The following is a description of a gene set: species: Homo sapiens Human Gene Set: WP_NOVEL_INTRACELLULAR_COMPONENTS_OF_RIGILIKE_RECEPTOR_PATHWAY Novel intracellular components of RIG-I-like receptor pathway, and this is the list of marker genes: MAP3K7, IFNK, CASP8, TNF, CASP10, DHX58, SIKE1, TKFC, STING1, IFNE, TRAF3, TBKBP1, DDX17, TRAF2, ISG15, ATG5, CYLD, ATG12, RNF125, CXCL10, IKBKG, IFIH1, RIGI (RNA sensor RIG-I), MAVS, IRF7, AZI2, NFKB1, MAPK12, NFKBIB, MAPK11, TRAF6, MAPK13, DDX3X, TRIM25, MAPK14, CXCL8, CHUK (component of inhibitor of nuclear factor kappa B kinase complex), TRADD, SNW1, MAPK10, IKBKB, CXCL12, IFNA1 (NCBI Gene Id 89955), NFKBIA, MAPK8, IFNG, IFNB1, NLRX1, IRF3, PIN1, IKBKE, RIPK1, FADD, OTUD5, MAP3K1, RELA, TANK, TBK1, MAPK9, DDX3Y